The following is a description of a gene set: Human Gene Set: GOBP_NEGATIVE_REGULATION_OF_RESPONSE_TO_DRUG Any process that stops, prevents or reduces the frequency, rate or extent of response to drug. species: Homo sapiens, and this is the list of marker genes: MIR185, MIR451A, MIR873, MIR130B, MIR34B, MIR495, MIR129-1, MIR133A1, MIR186, MIR9-1, MIR508, MIR1-1, MIR326, MIR133B